The following is a description of a gene set: studied in species Mus musculus Mouse Gene Set: GOBP_METHYLGLYOXAL_CATABOLIC_PROCESS The chemical reactions and pathways resulting in the breakdown of methylglyoxal, CH3-CO-CHO, the aldehyde of pyruvic acid., and this is the list of marker genes: Hagh, Pnkd, Glo1 (glyoxalase 1), Park7, Haghl, Gatd1